Given this list of marker genes armA, blaSHV-12, gyrB, acrB, macB, mdtF, rmtB, macA, emrE, tolC, tetA, KPC-2, AAC(6')-Ib, rmtD, tetB, rmtG, mdtE, rmtH, pef, qnr, gdx, oqxA, rmtC, acrA, gyrA, 16S rRNA, bla, mdfA, rmtF, here is a description of the gene set: species: Homo sapiens Resistance of microorganisms (bacteria, viruses, parasites) to antimicrobials is one of the most important public health problems. Infection with enterobacteria is treated with antibiotics from four groups (beta-lactams, aminoglycosides, tetracyclins and fluorquinolones). The main resistance mechanisms against these molecules are enzymatic degradation, efflux, inhibition of the drug's binding reaction, or usage of a back up pathway. Resistance against antiseptics and disinfectants is conferred by efflux proteins, biofilm formation or modification of targets. Resistance mechanisms are either acquired by mutation, by horizontal gene transfer, or are already intrinsic to the organism. Participation of the organism in a consortium (like in biofilms) enables additional resistance mechanisms. Reactome Pathway: Antimicrobial resistance part of: Action of antimicrobials and antimicrobial resistance